Given this list of marker genes PKP4, FAM186A, TXK, HEXA-AS1, ADRB2, SLC43A3, IPCEF1, HDAC11, CCL1, PKNOX2, SYCE1L, FPR2, NRG2, AVPR1A, IFITM1, COL11A1, KLRB1, SYNE1, MUC5AC, ALDH3B2, GABARAPL1, AKR1C1, RUSC1, PDE4A, ACP3, C5AR1, GLTP, FRMPD1, ABCG2, LAMA1 (NCBI Gene Id 3907), OR3A1, LAIR2, OSBPL2, BPY2, LCK, MADCAM1 (NCBI Gene Id 8174), SLC30A3, ITGAL, SGSH, SKAP1, TIAM2, CD247, LPP, USB1, ZNF362, SEMA4C, PITPNC1 (phosphatidylinositol transfer protein cytoplasmic 1), MMRN2, OTULINL (NCBI Gene Id 54491), EEF1AKMT3, GPR21, PDE6G, RPA1, DDX6, LPIN2, DNAJC4, RCAN1, ATP2B4, NPHS2, PITPNM3, BHLHE40, MT3, DOK2 (docking protein 2), NCAM1, NLRP3, KRT6A, TSHB, CRHBP, NRG1, HCG9, ALDH1A2 (aldehyde dehydrogenase 1 family member A2), VASH1, SYCP1, CACNA1F, C2, COQ6, MPP1, SECTM1, TPX2, CCNA1, CYP24A1, DHX16, KLHDC8A (NCBI Gene Id 55220), SASH1, GLRA2, LILRP2, LILRA3, VCL, PDGFD, THBS4, MAP2K7, REEP1 (receptor accessory protein 1), GRIN2D, CELSR2, UNC5B, ZNF702P, COLQ, ARHGAP35, PALLD, H4C7, TRIAP1, GSC2, SYNGR1, ELF3, CYP2C19, HTRA1, LIFR, ZDHHC8BP, XCR1, POU4F2, RALYL, KIF21B, ZMAT3, LRRTM4, ZDHHC18, PCDHB11 (NCBI Gene Id 56125), C1orf216, H2AC4, LGI2, PATJ, SCRIB, EPHA5, MSR1, PZP, ITM2A, CDH9 (NCBI Gene Id 51180), TBX10, CDH18, TSPAN1, KRTAP5-9, N4BP1, TXNRD1, MLXIP, F9, TYROBP, ADM2, HSPA6, OR12D3, SOX13, SPON2, TBC1D8, CD3D, PLEKHF1, SCAF4, EPS8L3, M6PR, LUZP4, RORA, CLU, ANOS1, PHOX2B, PPP2R5A, NKX2-1, ZCCHC4, SEC14L5, GH2, GPR107, SAA4, UBAP1, PEG3, ENOSF1, ARL4C, POMZP3, ADAM29, UBQLN3, KIR3DL1, CLUL1, SCARB2, CATSPERZ, GATA3, MTAP, MFGE8, POLD3, ALOXE3, TFR2, PKD1L1-AS1, BDNF, MXRA7, LRP1B, EXTL2, MB, TTF1, IQCA1, IGF2R, FNDC4, MUC1, AFF4, KCNE4, TPST2, ITK, ADM, FBXL7, NHLH2, CRB1 (crumbs cell polarity complex component 1), MYO7A, SAMHD1, FOXI1, here is a description of the gene set: In the present study we used Affymetrix oligonucleotide microarrays to produce gene transcription profiles for the major leukocyte types in humans. This comprehensive dataset enabled us to not only establish which genes were expressed in each leukocyte type, but also which genes were expressed in each subset after activation. The used of a comprehensive dataset of gene profiles from all the major human leukocyte subsets enabled a novel and powerful means for identification of genes associated with single leukocyte subsets, or different immune paradigms. Human Gene Set: GSE3982_BCELL_VS_NKCELL_DN from publication Jeffrey KL, Brummer T, Rolph MS, Liu SM, Callejas NA, Grumont RJ, Gillieron C, Mackay F, Grey S, Camps M, Rommel C, Gerondakis SD, Mackay CR (PMID 16474395) species: Homo sapiens Genes down-regulated in comparison of B cells versus NK cells.